The following is a description of a gene set: Human Gene Set: MORF_ETV3 Neighborhood of ETV3 species: Homo sapiens Neighborhood of ETV3 ets variant gene 3 in the MORF expression compendium, and this is the list of marker genes: MC5R, FNTB, SLC30A3, ITIH4, NCKIPSD, ERCC4, COX6A2, SLC13A2, GRIK5, ADCYAP1, LY9, PAX7, GJB5, MLN, NF1, KRT33B, ETV3, MAGEA9, GRIP2, TBX19, HOXD4, PIK3CB, RXRG (retinoid X receptor gamma), KRT33A, GLE1, ABO, KRT86, IVL, BMP10, TBC1D22A, ESR1, BCL2, ABCB9, PIGR, ARL3, SLC16A5, HTR1B, P2RX7, LTBP4, AFF2, CYP11A1, NXPE3, PRELID3A, POU6F1, EPHB2, PLEKHB1, SLC4A3, DPT, HTR7 (5-hydroxytryptamine receptor 7), CTRL, PAX9 (paired box 9), SYT5, SULT4A1, CHST7, KLHL18, AQP7, NRTN, MYO9B, MSX1, DNAJC16, DAPK2, UTRN, SLC2A1, DRC3, TNFRSF25 (NCBI Gene Id 8718)